The following is a description of a gene set: Mouse Gene Set: GOBP_GMP_BIOSYNTHETIC_PROCESS The chemical reactions and pathways resulting in the formation of GMP, guanosine monophosphate. studied in species Mus musculus, and this is the list of marker genes: Atic, Hprt1, Impdh1, Adsl, Paics, Gart, Ada, Ampd1, Pfas, Impdh2, Gmps, Ppat, Ampd2, Adk, Aprt, Pnp